The following is a description of a gene set: Any process involved in the maintenance of a steady-state level of a surface-active agent that maintains the surface tension of a liquid. studied in species Mus musculus Mouse Gene Set: GOBP_SURFACTANT_HOMEOSTASIS, and this is the list of marker genes: Oas1g, Abca3, Rcn3, Mbl2, Ctsh, Abca12, Pla2g4a (phospholipase A2, group IVA (cytosolic, calcium-dependent)), Mbl1, Napsa, Lpcat1, Oas1d, Oas1e, Oas1f, Oas1h, Nkiras1, Epas1, Adgrf5, Tmem63b, Kdr, Erbb4, Oas1c, Pthlh, Bpifa5, Sftpd, Lamp3, Bpifa1, Tmem63a, Oas1a, Itgb6, Fgf7, Nkiras2, Vegfa, Oas1b, Tgfb1